Given this list of marker genes Maea, Pstpip1, Myh9, Myh2, Septin2, Anln, Rtkn, here is a description of the gene set: A cytoskeletal structure composed of actin filaments and myosin that forms beneath the plasma membrane of many cells, including animal cells and yeast cells, in a plane perpendicular to the axis of the spindle, i.e. the cell division plane. In animal cells, the contractile ring is located at the cleavage furrow. In budding fungal cells, e.g. mitotic S. cerevisiae cells, the contractile ring forms at the mother-bud neck before mitosis. species: Mus musculus Mouse Gene Set: GOCC_ACTOMYOSIN_CONTRACTILE_RING